The following is a description of a gene set: Human Gene Set: CDPCR1_01 Genes having at least one occurrence of the motif NATCGATCGS in the regions spanning 4 kb centered on their transcription starting sites. This matches the CUTL1 transcription factor binding site V$CDPCR1_01 (v7.4 TRANSFAC). species: Homo sapiens, and this is the list of marker genes: COL2A1, MAG, BRINP3, FOXG1, STEAP2, NKX2-2 (NK2 homeobox 2), GATA4, PAX8, GRB7, SERPINI1, KCNS1, SERPING1, PIGP, LINC00173, TMEM237, AKIRIN2, NFIB, KCND1, CSMD3, MN1, NR2F6, ZNF503, CPNE6, KDELR2, THRA, MGAT5B, ZNF689, FCHSD1, DUSP4, STMN2, HOXC6, CREM, NOG, ETV1, RLF, STAT5B, MEIS1, EMP1, HOXC11, ATXN7L2, ZNF827, VAX1, PCGF2, NTRK1, NRXN3, PLA2G15, NTNG2, RFX4, TLE4, EEF1A2, GART, INSRR, ATXN7L1 (ataxin 7 like 1), HOXA10, AP3M2, GRIK4, NHLH2, TUG1, AK9 (adenylate kinase 9), BTBD3, IL1RAPL1, IL15, DIO2, HEXIM2, CELF4, HOXD10, ZNF516-DT, ERG, AMBP, SON, TBC1D14, CIB3 (NCBI Gene Id 117286, calcium and integrin binding family member 3), KAT7, KCNA1 (NCBI Gene Id 729214), TCF7L2, SFTPC, E2F8, HOXB4, PLXNA3, BARHL2, BRINP1, BHLHE41, TUBA4B, FGF12, RUNX1T1 (RUNX1 partner transcriptional co-repressor 1), NOL4, DPH1, MBNL1, GINS3, WDPCP, LIN28A, DYRK2, PPT2, RPH3A (NCBI Gene Id 22895), MAOB, PIGN, STAG2, PHF3, CDIN1, AGBL4, EXT1, KMT2A, EGR1, PDCD10, SIAH3, ST7, RTN4RL2, TUBA4A, SLC12A5, CYP26B1, ITGA7, NR3C2, CUL2, INSM2, HOXC5, TBX6, IKZF2, PTCHD1, NUCKS1, DPP10, PFN2, ADAM10, KLF15, HOXB2, TRIB2, TBX3, DGKB, PRR35, NOVA1